The following is a description of a gene set: studied in species Homo sapiens Human Gene Set: AREB6_01 Genes having at least one occurrence of the motif NNYNYACCTGWVT in the regions spanning 4 kb centered on their transcription starting sites. This matches the TCF8 transcription factor binding site V$AREB6_01 (v7.4 TRANSFAC)., and this is the list of marker genes: NRXN2, HOXB6, TMEM125, S100A14, GNAT1, SLITRK4, HCLS1, IGFBP6, PCP4, TUBA4B (NCBI Gene Id 80086), USP2, ENOX1, CCDC14, TSPAN6, LIN28A, SMG1, PAK6, NTPCR, STX1A, PDGFB, ADAMTS19, ID4, SIPA1, ARRDC3, MAP7, STRC, LRP10, LAMB3, SNX13, ACTN3, C1QA, TRPM7, CXXC5, CLHC1, TUBA4A, MPV17, NXPH4, EGR4, TDRD3, OPHN1, VWF, PURA, OSR1, STK35, TMEM139, VAT1, NFIB, TTC39B, BTG4, LAMTOR1, KIF12, FGF17, ARHGEF39, HNF1A, GRHL2, ACTA1, TFAP2A, ETV4, PCDHGA5, NBEA, KREMEN2, BMF, IGF2BP1, CASK, BHLHE41, ZNRF1, ALDH1A1, IL12B, GSDMA, FOXD3, TTLL6, CLDN5, YARS1, HES7, CHRM1, CLDN7, THRA, ENHO, FLNB, RFFL, DDX17, PLAG1, TAFA1, EHF, DIAPH1, MAP3K5, NKX2-1, GSE1, IRX4 (NCBI Gene Id 50805), ZIC4, IL2, JUP, TRIB1, HCRTR1, ACVR2A, LRFN4, AFF3, EVC2, KIR3DX1, SHH, ZBTB37, SKIDA1, PCDH7, RNF38, HDAC9, SPACA6, RASGRF2, HEPH (hephaestin), LYG2, EDC4, FBXW11, LRCH4, TMEM62, RUNX1T1, ZNF593, HIF1A, IGSF9B, JADE2, SLC4A11, CEMIP, NOL4, DNMT3A, LSP1, ANKHD1-EIF4EBP3, CABP7, INPP5F, SLC16A6, CRELD1 (cysteine rich with EGF like domains 1), TMEM191A, IL7, MICAL2, PAQR9, SOX10, ZIC1, SAMD7, SP6, IQGAP2, PTCHD1, PROX1, PCGF1, NKX6-1, CYP26B1, FNBP1L, SLC7A11, CTHRC1, HOATZ, C6orf47, TEX47, DDR1, ADAMTSL1 (ADAMTS like 1), SLC44A1, NOSIP, TP63, GPR119, LYPD3, ADGRA2, JPT1, ACSL4, CAMKK1, KCNH7, CDH13, RARA, PRRG2, PXN, PWWP3B, ZC3H10, HPCAL4, S1PR1, GRK6, CRTAM, TMED1, RTN1, IFT52, DSG3, SLC16A8, SOCS5, OLFML2A, NRXN3, SENP1, DLL4, BCL9L, PAX7, CDK2AP2, LLGL2, TNFRSF13C, ARHGAP32, SFRP2 (secreted frizzled related protein 2), ACAN, LRRFIP2, PPARGC1A, TMEM151A, IFNK, SCAND1 (NCBI Gene Id 92786), ANKRD1, KCND1, STRN4, CADM2, FKRP, NPAS2, TLK2, ITGB8, SLC6A11, GAD1, FAM72A, MOV10, LAMC2, CCDC140, CREB5, SPDEF (SAM pointed domain containing ETS transcription factor), EPB41, EIF5, TBC1D5, H1-9P, RPS27A, REV3L, TSSK2, USO1, SECISBP2, KCNH3, LNX2, CHCHD7, IL27, SRSF7, BRD2, SAMD12, ZNF296, PC, EPS8L1, HS6ST3, GABARAP, CSAD (cysteine sulfinic acid decarboxylase), CRB3, DCHS2, TMEM38A, MCAM, ANKHD1, S100A9, RBMX2, LMNTD2, RPRD2, CDKN1B, G3BP2, ETV3, EML3, HOXD8, ITGB3BP, CELF1, FXYD3, NRP1, FOS, KRT8, PHF21B, SOSTDC1 (sclerostin domain containing 1), POLR1D, ESRP2, UBXN10, UBE2D1, SLC26A10P, CCDC120, CEL, RABL6, UNC45A, SYT3, ERLIN1, MANF (mesencephalic astrocyte derived neurotrophic factor), CSMD3, WNT3A, FBXO24 (F-box protein 24), FGF5, UMOD, RRAD, LDB2, PAX3, TEF (NCBI Gene Id 85370)